Given this list of marker genes UBE2C, UBE2D1, UCHL3, UBE2L3, UBE2E3, UBA1, UBE2T, UBE2S, USP7, OTULIN, USP9X, USP5, CDC34, UBE2Q2, UBA52, UBE2D2, UBB, UBA6, UBE2G2, UBE2G1, RPS27A, UBE2E1, UBE2W, UBE2A, UBE2Z, UBE2H, UBE2R2 (ubiquitin conjugating enzyme E2 R2), UBC, UBE2K, UBE2B, here is a description of the gene set: Reactome Pathway: Synthesis of active ubiquitin: roles of E1 and E2 enzymes Ubiquitin monomers are processed from larger precursors and then activated by formation of a thiol ester bond between ubiquitin and a cysteine residue of an E1 activating enzyme (UBA1 or UBA6, Jin et al. 2007). The ubiquitin is then transferred to the active site cysteine residue of an E2 conjugating enzyme. Precursor proteins containing multiple ubiquitin monomers (polyubiquitins) are produced from the UBB and UBC genes. Precursors containing a single ubiquitin fused to a ribosomal protein are produced from the UBA52 and RPS27A genes. The proteases OTULIN and USP5 are very active in polyubiquitin processing, whereas the proteases UCHL3, USP7, and USP9X cleave the ubiquitin-ribosomal protein precursors yielding ubiquitin monomers. Other enzymes may also process ubiquitin precursors. A resultant ubiquitin monomer is activated by adenylation of its C-terminal glycine followed by conjugation of the C-terminus to a cysteine residue of the E1 enzymes UBA1 or UBA6 via a thiol ester bond. The ubiquitin is then transferred from the E1 enzyme to a cysteine residue of one of several E2 enzymes. part of: Protein ubiquitination studied in species Homo sapiens